Given this list of marker genes ANXA8, TRIM72 (NCBI Gene Id 493829), ANXA13, OSBPL5, GRAMD1B, SYT1, ANXA9, SCARB1, PLEKHN1, GAP43, ANXA7, GSDMB, ANXA6, SYT5, SYT9, ANXA1, GSDMA, GSDMC, ANXA4 (NCBI Gene Id 307), MFGE8, OSBPL8, ADGRB1, RPE65, SESTD1 (NCBI Gene Id 91404), TREM2, GAS6, CPNE6, ANXA2P2, HAVCR1, ANXA2, APPL1, CAVIN2, SMPD3, ANXA11, MME, JPH2, CPNE1, OSBPL10 (NCBI Gene Id 54907), ANXA3, SCIN, TLN1, ANXA10, HMGB1 (NCBI Gene Id 3146), SYTL2, APPL2, AXL, SCARB2, ANXA8L1, FCHO2, MARK1, CD300A, PLCD1, CD300LF, RS1, SYT10, ANXA5, THBS1, TIMD4, GSDMD, here is a description of the gene set: studied in species Homo sapiens Human Gene Set: GOMF_PHOSPHATIDYLSERINE_BINDING Binding to phosphatidylserine, a class of glycophospholipids in which a phosphatidyl group is esterified to the hydroxyl group of L-serine.